Given this list of marker genes Adamts17, Aqp6, Serbp1, Cd81, Prss44, Kcnj2, Ghr, Ywhaz, Mrpl13, Gabra6, Ube2g1, Eif2b3, Lhfpl2, Pkd2, C2cd5, Atxn1l, St18, Zfp641, Epha6, Otc, Unc79, Fsd1l, Acr, Dennd5b, Memo1, Cdh7, Sox14, Baz1a (bromodomain adjacent to zinc finger domain 1A), Il12b (NCBI Gene Id 16160), Eif5, Uhrf2, Sp4, Hyal4, Erbb4, Hipk3, Erich6b, Grem2, Itpripl1, Zmynd19, Zfp704, Pam, Smarca5, here is a description of the gene set: Genes predicted to be targets of miRBase v22 microRNA mmu_miR_7065_5p in miRDB v6.0 with MirTarget v4 prediction scores > 80 (high confidence targets). Mouse Gene Set: MIR_7065_5P species: Mus musculus from publication Chen Y, Wang X (PMID 31504780)